The following is a description of a gene set: Human Gene Set: GSE15330_LYMPHOID_MULTIPOTENT_VS_GRANULOCYTE_MONOCYTE_PROGENITOR_DN from publication Ng SY, Yoshida T, Zhang J, Georgopoulos K (PMID 19345118) species: Homo sapiens Genes down-regulated in lymphoid-primed multipotent progenitors versus granulo-monocyte progenitors. Regulation of lineage potential and transcriptional priming by Ikaros. New insight is provided into a bivalent regulation of lineage priming in the HSC and its lympho-myeloid restricted progeny the LMPP by the lymphoid lineage-determining factor Ikaros Whereas Ikaros is responsible for the activation of a cascade of lymphoid expression programs and for the establishment of lymphoid potential from the HSC to the LMPP it is also responsible for the repression of stem cell and erythroid genetic programs that are incompatible with further lineage restrictions emanating from the LMPP, and this is the list of marker genes: RNGTT, RNF14, SEPTIN8, CMTR1, MTMR4, CUTA, LAMTOR3, RECQL, RNASEL (NCBI Gene Id 6041), FLT3LG, MGME1, UBAC1, USP39, SERPINI1, MRPL14, PRPS1 (phosphoribosyl pyrophosphate synthetase 1), BEX3, WIPF1, TMCC2, TXNRD2, PRXL2C, ATP5PB (NCBI Gene Id 515), PLEC, PRDM5, CD48, NDUFA8, GTPBP2, HDLBP, SSBP4, MBNL3, SCAF11, ZBTB14, EGLN3, TANC1, DCTN2, PTPN1, GLOD4, RCSD1, RNF5, SLF1, NRDE2, TTC7B, TRPV2 (NCBI Gene Id 51393), GEMIN2, TLCD2, SERPINE2, ACYP1, COX5A, TMEM9B, GALE, SLAIN1, IPP, DOCK8, GRN, RBM10, CA2, ITGB1BP1, CYB5A, LCLAT1, SAAL1, DHX57, APOBEC1, HAUS1, MRPL10, SLC4A8, IL2RB, PARP9, CAPN10, YIPF3, FMNL1, CTNNA1, FERMT3, GLTP, CPT1A, INSL6, PHKB, RAB22A, ANAPC13, DYNLRB1, TNFSF11, MRPL46, ACP2, NDUFS2, BSCL2, DCAF15, PRXL2A, TMEM129, RMND1, G3BP2, IMPA1, ZDHHC12, TDP2, STAT4, TMEM134, CXCL13, FANCG, CLPP, SUPT20H, ILK, NIBAN2, EIF4E3, NUP88, CHFR, RAD21, USF1, CAMK4, ACSF3, ATE1, OSGIN2, IPO9, ATP5F1A, MYL10, CDKN1B, EBPL, CFAP20, FNTA, CLPB, DUSP10, GLRX, DEK, LMNB1, BIRC2, KLHL7, IDH2, TUBB4B, MPC1 (mitochondrial pyruvate carrier 1), CAPG, IDNK, SARAF, TMCO6, KCTD1, VRK2, MAD1L1, GPSM3, CNIH1 (cornichon family member 1), PIGR, ZNF808, NFIA, PHGDH, PBDC1 (NCBI Gene Id 51260), ZNF518B, NEK7, YIPF4, PPIB, TOR3A, IFT27, IFTAP, PPP1R3C, MTMR14, IL15, ANGPTL4, ANAPC1, SPAG5, IQGAP3, ABHD4, PFKL, AGL (NCBI Gene Id 178), GMPR, TMEM216, NT5C, MPDU1, CDKN2AIPNL, OSTF1, APOOL, CNOT9, EHD4, HRAS, CLDND1, SMARCAL1, CAPZA1, RABGAP1L, GJA1, MFSD6, BSG, SERPINB9, ASRGL1, ATCAY, AP3S1, CD38, CALHM2, TSPAN13, DNAJC15, MRPL50, GRHPR, HNRNPUL1, RBM7, IGSF9, PANX1, RYK, PEA15, EEF1AKMT1, C16orf87, DXO, SAT1, MXI1, PLEKHA2, CD109, FAH, STARD3NL, HERPUD1